Given this list of marker genes ZNF503, IGFBP5, DPT, PITX2, F3, LINC01173, IHH, LCP1, GOLGA8G, LINC01705, LUM, PDLIM7, PAMR1, PRICKLE2, LEF1, SRPX2, KLHL4, EPYC, LYPD1, ARID3A, NR2F1-AS1, IL1R1, RBM24, PI15, KANK1, IGF2BP3, PRAG1, ST6GAL2, SEMA3C, CRISPLD2, SLC26A2, RDH10, SLC1A3, SERPINE1 (serpin family E member 1), NOG, TYRP1, HAPLN1, COL5A2, RGCC, EPHB2, PHLDB1, COL3A1, TPM4, CLIC3, MAGED4B, LFNG (NCBI Gene Id 3955), ALDH7A1, NKD2, here is a description of the gene set: Transcriptome of human HepaRG hepatocellular carcinoma liver progenitors in responses to a WNT3A-enriched microenvironment and dissection of pathways dependent on _-catenin and/or blocked by the SFRP-like Wnt inhibitor FZD8_CRD. from publication Mebarki S, Désert R, Sulpice L, Sicard M, Desille M, Canal F, Dubois-Pot Schneider H, Bergeat D, Turlin B, Bellaud P, Lavergne E, Le Guével R, Corlu A, Perret C, Coulouarn C, Clément B, Musso O (PMID 27191501) Methods: Liver progenitor cells were incubated in a WNT-enriched microenvironment for 72hrs (200 ng/ml mouse recombinant purified Wnt3A from R&D Systems). Gene pathways dependent on downstream _-catenin were studied by _-catenin knockdown with specific siRNA. Gene pathways blocked by extracellular SFRP-like Wnt inhibitors were studied by co-incubating cells with recombinant purified FZD8_CRD (300 ng/ml, from R&D Systems). Independent culture experiments performed in triplicate include untreated cells or cells incubated with scrambled siRNA or with _-catenin-specific siRNA or with FZD8_CRD, alone or in combination with Wnt3A. studied in species Homo sapiens Human Gene Set: MEBARKI_HCC_PROGENITOR_WNT_UP_CTNNB1_DEPENDENT_BLOCKED_BY_FZD8CRD